The following is a description of a gene set: studied in species Homo sapiens Enables the transfer of fructose from one side of a membrane to the other. Fructose exists in a open chain form or as a ring compound. D-fructose is the sweetest of the sugars and is found free in a large number of fruits and honey. Human Gene Set: GOMF_FRUCTOSE_TRANSMEMBRANE_TRANSPORTER_ACTIVITY, and this is the list of marker genes: SLC2A8, SLC5A10, SLC2A9, SLC2A2, SLC2A6, SLC2A11, SLC2A7, SLC2A3, SLC2A5